The following is a description of a gene set: Human Gene Set: GSE21927_SPLEEN_MONOCYTE_VS_GMCSF_GCSF_BONE_MARROW_UP studied in species Homo sapiens from publication Marigo I, Bosio E, Solito S, Mesa C, Fernandez A, Dolcetti L, Ugel S, Sonda N, Bicciato S, Falisi E, Calabrese F, Basso G, Zanovello P, Cozzi E, Mandruzzato S, Bronte V (PMID 20605485) Tumor growth is associated with a profound alteration of myelopoiesis, leading to recruitment of immunosuppressive cells known as myeloid-derived suppressor cells (MDSCs). Analyzing the cytokines affecting myelo-monocytic differentiation produced by various experimental tumors, we found that GM-CSF, G-CSF, and IL-6 allowed a rapid generation of MDSCs from precursors present in mouse and human bone marrow (BM). BM-MDSCs induced by GM-CSF+IL-6 possessed the highest tolerogenic activity, as revealed by the ability to impair the priming of IFN- -producing CD8+ T cells upon in vivo adoptive transfer. Moreover, adoptive transfer of syngeneic, GM-CSF+IL-6-conditioned MDSCs to diabetic mice transplanted with allogeneic pancreatic islets resulted in long term acceptance of the allograft and correction of the diabetic status. Cytokines inducing MDSCs acted on a common molecular pathway. Immunoregulatory activity of both tumor-induced and BM-derived MDSCs was entirely dependent on C/EBP transcription factor, a key component of the emergency myelopoiesis triggered by stress and inflammation. Adoptive transfer of tumor antigen-specific CD8+ T lymphocytes resulted in therapy of established tumors only in mice lacking C/EBP in myeloid compartment. These data unveil another link between inflammation and cancer and identify a novel molecular target to control tumor-induced immune suppression. We used gene expression analysis to identify those factors, secreted by tumor-infiltrating MDSC, which could drive emathopoiesis. Moreover we compare gene expression profile of tumor-induced MDSC, obtained from either the spleen and the tumor infiltrate of tumor bearing mice, and in vitro bone marrow-derived MDSC. Genes up-regulated in CD11b Spleen from BALBc mouse versus CD11b BoneMarrow from BALBc mouse incubated with GMCSF and GCSF., and this is the list of marker genes: TMEM19, HYCC1, LINC00926, RBMS1, FMN1, NPHP3, FITM1, RASA3, B9D2, BCL7A, FBXW12, ARL4C, PRR11, SLC1A4 (NCBI Gene Id 6509), CMTM3, NUP210L, C15orf40, FAM111B, ARHGAP32, ZNF780B, GS1-600G8.3, RASA1, HEMGN, KMO, TJAP1 (NCBI Gene Id 93643), CCDC30, SYNGR1, CNKSR2, ERCC5, H2AC8, GULP1, SETDB2, CD40 (CD40 molecule), GCOM1, TRPC1, UMPS, RNASEH1, EBLN3P, EXT1, TIPIN, NIBAN3, SLC6A16, TAPBPL, ANKRD44, BBS12, MYLIP (NCBI Gene Id 29116), RBM5, BRD7, CFAP119, H2BC8, ZBED5, USP7, KRT222, DAPP1, PLXNA1, METTL18, SPON2, FCAR, SHOC1, PRDM7, SLC25A45, TMEM192, ACSM3, ZNF646, ZNF561, JUN, MMUT, ZC3H12B, DOCK8-AS1 (DOCK8 antisense RNA 1), CYP26A1, WDR74, CENPW, TSPAN15, AGBL3, ZNF674, ACAD10, FAM229B, GNA11, CARF, CYP2C19, ZNF709, CENPBD1P, ALG13, EPCIP, MAMDC2, KIF27, TSPAN31, GVQW3, RPS20, MTSS1, OR10A4, LINC00475, TMLHE (NCBI Gene Id 55217), LINC00518, CBX3P2, KIAA1586, ZNF134, MPC1, ITGB3BP, SCN3A, ZEB1, TRAK2, COA5, MOGAT1, TMEM263, ZC4H2, GK3, CLGN, SMU1, PDCD4-AS1, MANSC1, LINC00240, SATB1, WDR19, CCDC82, ANKRD23, DNAJA3, KRT18, NDE1, OARD1, AIDA, GPX5, FZR1, ARSB, TNFRSF10C, MXI1, MRPL51, MRAS, NDUFV3, TMEM123, LINC01242, SLC40A1, RAPGEF4-AS1, NEXN-AS1, FADS1, ATRNL1, SMIM10, VIPAS39, KLHDC8B, TSPAN13, ZNF407-AS1, CD8B, NUDT12, RAB30, SLC35E1, BBS4, ZNF829, CYP2R1, TRABD2A, TRIM54, LBX1, SPTSSB, LINC02145, TRIM38, FLACC1, SERPINA1, ADARB1, PROSER3, PRKAA2, SLC19A2, ADAM30 (NCBI Gene Id 11085), APBB2, DNAJC7, APOBEC3C, SLC39A10, ZNF611, TENT5A, LINC00339, CAV2, RP9P, BTBD9, EPB41L3, PRKCE, RFTN1, AKAP12, DZIP3, TCL1A, SLC25A14, ABCB1, HNRNPA2B1, IRF4, LHFPL1, ZNF791, ABCB4, AVIL, CCNT1, GNB4, IKZF2, ZNF252P